Given this list of marker genes URB2, NFE2L1, SNORD48, HES1, LZIC, BCL7B (BAF chromatin remodeling complex subunit BCL7B), ABHD17A, NFE2L1-DT, LTV1, LIG4, G6PC3, VPS33A, MRPL46, WDR81, PEPD, KIF9, LARP4, TTC1, FKBP1A, MIA3, ARMC8, EXOC2, GSTCD, ADCK1, NDOR1, EIF4E2, CEP57L1, TAF3, COMMD4, INTS12, TIGAR, FAM118B, VPS50, KLHL18, CPSF2, CCND3, DUSP3, MTHFD1L, SESN1, MIR22HG, TSEN15 (NCBI Gene Id 92120), RPUSD4, TAF5L, PPIC, KAT6A, NDUFB1 (NADH:ubiquinone oxidoreductase subunit B1), ATP6V0D1, VTI1B, IFRD2, ATP6V0B, SNX19, OXNAD1, SNHG32 (small nucleolar RNA host gene 32), CRY1, GART, KMT5B, PIK3IP1, CLCN7, TIGD1, KPNA2 (karyopherin subunit alpha 2), HSPBAP1, ATP6V0D1-DT, MAPKAP1, ABTB2, VARS1, NMNAT1, ANKRD40, DPH3, MRPS11, SLC49A4, TMEM203, here is a description of the gene set: species: Homo sapiens Genes containing one or more binding sites for (ZNF704) in their promoter regions (TSS -1000,+100 bp) as identified by GTRD version 20.06 ChIP-seq harmonization. Human Gene Set: ZNF704_TARGET_GENES from publication Yevshin I, Sharipov R, Kolmykov S, Kondrakhin Y, Kolpakov F (PMID 30445619)